The following is a description of a gene set: An epigenetic gene silencing mechanism in which chromatin is compacted into heterochromatin, resulting in a chromatin conformation refractory to transcription. This process starts with heterochromatin nucleation, its spreading, and ends with heterochromatin boundary formation. studied in species Mus musculus Mouse Gene Set: GOBP_HETEROCHROMATIN_FORMATION, and this is the list of marker genes: Suv39h1 (suppressor of variegation 3-9 1), Hdac3, H2al1n, H1f0, Dyrk1a, Lmna, Tex15, Hdac8, Wdhd1, Hells, Hnrnpk, Ehmt1, Spen, H2ac8, H2az2, Pole3, Baz1a, H1f9, Lmnb2, H2al1k, Sirt6, Spin1, Cdyl, Lbr, H2ab2, Dicer1, Dot1l, Hat1, Cbx3, Pphln1, H2ab1, Tdrd12 (tudor domain containing 12), Mbd1, Cdk2, Mphosph8, Phf2, Ezh2, Hdac2, H2ac22, Bend3, Pcgf5, Baz2a, H2al1f, Upf3b, Hotair, Mbd3, Smarca4, Mbd3l2, H2ac23, Pcgf3, H2ac19, Spty2d1, Tsix, Tdrd5, Rlf, Arb2a, Cenpv, Mbd2 (methyl-CpG binding domain protein 2), H2al1m, Ythdc1, Morc1 (NCBI Gene Id 17450), Kat8, Jarid2, Bap1, Trim28, Phf8, H2al1b, Trip12, Kmt2d (NCBI Gene Id 381022), H2ac20, Smarca5, Tdrd9, Spocd1, Morc2a, H2az1, H2ac1, Nrde2, Bahd1, H2ax, Cbx5, H2al3, Cbx8, Piwil4, Smarcad1, Kmt2b, Cbx1, Macroh2a1, Uhrf1, Atrx, L3mbtl1, Brca1, H2ac12, Lmnb1, Ubr2, Sin3a, Gm38999, H2ac11, Smarca2, Uty, Rlim, Setdb1, Smchd1, H3f3b, Smyd5, H2ac15, Eed, Eif1, Mettl3, H2aj, Dnmt1, Prdm14 (PR domain containing 14), H2ab3, Smarca1, Scmh1, Tasor, Mbd3l1, Tnp1, Hdac1, H2ap, H2ac13, Kdm5a, Piwil1, H3f3a, H2ac7, H2ac24, H2ac10, Ppm1d, Ezh1, Rb1, H2al2a, Ftx (Ftx transcript, Xist regulator, non-protein coding), Ehmt2, Mis18a, Atf7ip, H2ac6, Sirt2, Suz12, Tpr, Sirt1 (sirtuin 1), Fkbp6, Piwil2, Macroh2a2, Dnmt3b, Bcl6, Upf3a, H2al1o, Mecp2, Exosc10, Rif1, Ddx4, Jpx, Rbm15, Ncor2 (nuclear receptor co-repressor 2), Kmt2a (lysine (K)-specific methyltransferase 2A), Ctcf, Dnmt3l, H2al1j, Bmi1 (NCBI Gene Id 12151), Hmga2, Xist, Ubr5, Mael, H2al2b, Rbm15b, Rrp8, Upf1, Mov10l1, Dnmt3a, Resf1, Airn, H2al1e, Hnrnpu, Zfy2, H2ac25, Lrif1, Znfx1, H2ac4, Tdrd1, H2ac21